Given this list of marker genes GATA6, SCN5A, CACNA2D1, LDB3, PIGU, SCNN1A, MYH7, PSEN1, LMOD2, BANF1 (NCBI Gene Id 8815), POMT2, GATA4, ACTC1, TRPM4, MYOZ2, CACNB2, MYBPC3, MYL2, ATP6V1E1, PPP1CB, CITED2, HCN4, NPPA, CNBP, DUX4, FHL1, GLA, SCN3B, PRKAG2, SCN10A, DYSF, SEMA3A, SLMAP, NKX2-5, DSG2 (NCBI Gene Id 1829), BRAF, GNAI2, CTNNA3, KCNJ8, CDH2, MT-CYB, GPC3, TBX20, KCNE5, FLNC, TLL1, RANGRF, PTPN11, PSEN2, DMPK, SCN2B, SMCHD1, TNNC1, PKP2, GYG1, EXOSC5 (exosome component 5), FRG1 (FSHD region gene 1), KCND3, TNNI3K, GPC4, RAF1, SCN1B, DNMT3B, DUX4L1, TNNT2, AKAP9, CACNA1C, MYH6, JUP, LMNA, KCNK3, PLEC, LEMD2, POLG2 (DNA polymerase gamma 2, accessory subunit), KCNE3, RNASEH1, ABCC9, GPD1L, here is a description of the gene set: species: Homo sapiens Human Gene Set: HP_BUNDLE_BRANCH_BLOCK Block of conduction of electrical impulses along the Bundle of His or along one of its bundle branches. Bundle branch block